The following is a description of a gene set: Genes down-regulated during in vitro maturation of CD14+ monocytes (day 0) into immature (day 7) and mature dendritic cells (day 14). Dendritic cells (DCs) are antigen-presenting cells that play a major role in initiating primary immune responses. We have utilized two independent approaches, DNA microarrays and proteomics, to analyze the expression profile of human CD14(+) blood monocytes and their derived DCs. Analysis of gene expression changes at the RNA level using oligonucleotide microarrays complementary to 6300 human genes showed that approximately 40% of the genes were expressed in DCs. A total of genes (4%) were found to be regulated during DC differentiation or maturation. Most of these genes were not previously associated with DCs and included genes encoding secreted proteins as well as genes involved in cell adhesion, signaling, and lipid metabolism. Protein analysis of the same cell populations was done using two-dimensional gel electrophoresis. A total of 900 distinct protein spots were included, and 4% of them exhibited quantitative changes during DC differentiation and maturation. Differentially expressed proteins were identified by mass spectrometry and found to represent proteins with Ca(2+) binding, fatty acid binding, or chaperone activities as well as proteins involved in cell motility. In addition, proteomic analysis provided an assessment of post-translational modifications. The chaperone protein, calreticulin, was found to undergo cleavage, yielding a novel form. The combined oligonucleotide microarray and proteomic approaches have uncovered novel genes associated with DC differentiation and maturation and has allowed analysis of post-translational modifications of specific proteins as part of these processes. from publication Le Naour F, Hohenkirk L, Grolleau A, Misek DE, Lescure P, Geiger JD, Hanash S, Beretta L (PMID 11279020) species: Homo sapiens Human Gene Set: LENAOUR_DENDRITIC_CELL_MATURATION_DN, and this is the list of marker genes: NAP1L4, ELK3 (ETS transcription factor ELK3), SF3B4, S100A8, S100A4, SOD2, LHFPL2, H4C3, PTAFR, CES1, CD163, NMB, IL1R2, EMP1, SERPINF1, CXCL3, SERPINA1, ARHGDIB, C3, PF4, ME1, ADAM10, PDLIM7, CYTIP, SLC11A1, NUP214, CTSK, LST1, ITPR1, FYB1, GSR, IDS, ZFP36L2, TNF, SPINK1, DHX8, CTBP1, CCR2, CD14, BRD2, ALG3, SLC1A3, TXNIP, ITGAL, PPIB, CLEC2B, C5AR1, TAX1BP3, IL2RG, BTG2, AKR1C1, AMPD3, FCGR2A, LTA4H, LGALS2, SDC2, TSC22D1, OLR1, S100A12, SORL1, ISG15, DOK1 (NCBI Gene Id 1796), PPIF, KRT10, MMP9, MICB, C3AR1, ANPEP, LYZ, ATP2A3, CD180, H2BC6, S100A9, CYBB, RTN1, SDF2, TLR1, GK, CXCL2, CXCL8, SREBF2, IRF7, SOS2, CSF1R, FGL2, CD37, NCOA4, TAL2, MAPKAPK2, PSEN1, IL6R, RO60, SNX17, PLSCR1, NCF1, CORO1A, BST1, TNFRSF1B, NFKBIA, CXCL5, PUF60, TUBA4A, NFYC, NAMPT, PLAUR (NCBI Gene Id 5329), LGMN, HSD17B10, RAB3GAP1, CHI3L1 (chitinase 3 like 1), PPP2R5D, PPBP, UPK2, MARCKSL1, NINJ1, DUSP6, BCAT1, STAB1, PRRC2A, FBP1, FCN1, CD44, FCER1G, HTRA1, IL1B, EMP3, KYNU, EVI2A, IER3, PTK2B, GLA